Given this list of marker genes Smarca5, Setd5, Slc38a2, Mtmr3, AI182371, Trim42, Zfp84, Zfp874b, Hecw2, Ccdc171, Dlg3, Aspm, Lin28b, Six6, Prkcd, Rassf1, Nup35, Cdh7, Rbm41, Smco1, Tmem65, Crem, Carnmt1, Pou4f1, Ranbp6, Strbp, Hs3st3b1, Cpsf6, Zfp715, Pes1, Rnaseh2a, Eea1, Pgap6, Dnajc13, Ifna13, Srpk2, Nup58, Clasp2, Zbtb10, AI597479, Usp45, Fam91a1, Tead1, Gvin3, Crybg3, Zeb1, Atxn1l, Apool, Hipk1, Homer1, Nlk, Akap7, Aicda, Col17a1, Ifi44, Cdc14a, Pcgf5, Kif1b, Kcnj13, Irs1, Carf, Ccnt2, Gria2, Uty, Slc16a10, Riok3, Zfand5, Tube1, Get1, Zfp811, Vstm2a, Aass (NCBI Gene Id 30956), Unk, Jun, Oas3, Lrrc2, Mis18a, Ube2o, Tbpl2, Cnr1, Mrtfa, Irgm2, Phf20, Ccpg1, Rhoq, Psmc6, Peak1, Chd2, Mospd2, Gtse1, Itpr1, Rb1cc1, Sepsecs, Cysltr1, Cask, Nr3c2, Arid2, Txndc16, Fndc3b, Shld2, Rora, Cltc, Scn2a, Igf1, Cpeb2, Cdh11, Csnk1g3, Tma16, Ccdc169, Lmo3, Rab11a (NCBI Gene Id 53869), Zbtb44, Sgms1, Stag2, Cstf3, Smco3, Lemd3 (LEM domain containing 3), Npat, Rorb, Acap2, Lypd1, Bpnt2, Tent4a, Lman1, Wdr43, Phf8, Cdk7, Paxbp1, Kat6a, Secisbp2l, Aldh1l2, Pfkfb2, Rasa2, Or52n4, Psmb1, Sh2d3c, Lrrtm2, Epb41l5, Ppp1r21, 1810037I17Rik, Klf15, Zfp148, Ptpn2, Ubr3, Exph5, Gucy1b1, Drd1, Csnk1g1, Mcur1, Iws1, Dusp16, Ccdc103, Itga2, Slc22a23, Srp14, Bcl6, Zfr, Trhde, Tmem132b, Rftn2, Grm1, B3galt2, Ppfia1, Nxt2, Slc4a1ap, Stard13, Snx27, Ino80d, Setbp1, Ahr, Nxph2, Katnbl1, Zfp446, Slc38a1, Atf1, Zswim6, Btaf1, Tfap2b, Ptprb, Zfp354a, Magi1, Lurap1l, Vwa5a, Crebrf, Lmo4, Jpt2, Rab22a, Chrng, Pdgfd, Birc6, Suco, Clic5 (chloride intracellular channel 5), Rab1a, Pou6f2, Hspa13, Prlr, Oip5, Dnph1, Adgrg2, Pdgfra, Ndnf, Slfn4, Daam1, Dennd4a, Klf11, Ppp1r9b, Pkd2, Gmfb, Tnrc6c, Arhgap19, Grem2, Cdk5r1, Ect2, Hsd17b12, Prkacb, Mospd1, Vcam1, Sostdc1, Cul3, Creb1, Sgpp2, Map3k4, Dmxl1, Abi2, Zfp53, Max, Mrpl39, Cetn3, Actg1, Lonrf1, Ugt8a, Irf2bp2, Gata3, Gabra1, Cox16, Dnajc19, Tbcel, Asph, Cemip, Mapk8ip3, Zfp951, Agps, Golim4, Chek1, Gpcpd1 (glycerophosphocholine phosphodiesterase 1), Rfx8, Chd9, Arpc5l, Nhlrc1, Avpr1b, Atoh1, Chmp1b2, Eri1, Dhrs7, Dimt1, Bnip2, Ppat, Ppp4r3b, Macir, Rnf180, Ube3a, Zfp503, Zfp462, Rimklb, Insm2, Tmem33, Slc16a9, Rsbn1l, Brms1l, Ms4a4b, Ednra, Tpgs2, Tigd5, Rnf44, Ski, Api5, Kifbp, Ylpm1, Neurog2, Abi3bp, Synj1, Apc, Glrb (NCBI Gene Id 99751), Cntn5, Cdh2, Cenpi, Snx30, Sirt1, Arl14ep, Neu4, Upp2, Pbrm1, Dclk1, Klf4, Runx1, Mei4, Col25a1, Nwd2, Cd209a, Ahcyl2, Plch1, Dsel, Syt16, Senp7, Tmem196, Dhx15, Enox1, Ndufs1, Glo1, Spink5, Kmt2c, Nxpe3, Setd1b, Rusc2, Phip, Asxl2, Cd300a, Dop1b, Psd3, Rab9, Kctd4, Phlpp2, Lrat, Tas1r3, Plaa, Qtrt2, Pnn, Etfbkmt, Kdm2b, Tmed5, Ncoa1, Mosmo, Irf2bpl, Ptgdr, Hook3, Zfp36l2, Intu, Mblac2, Sox9, Polr3d, Enpp4, Sp1, Fgfr2, Spata13, Hivep1, Klf6, here is a description of the gene set: studied in species Mus musculus Mouse Gene Set: MIR_466B_3P_MIR_466C_3P_MIR_466P_3P Genes predicted to be targets of miRBase v22 microRNA mmu_miR_466b_3p, mmu_miR_466c_3p, mmu_miR_466p_3p in miRDB v6.0 with MirTarget v4 prediction scores > 80 (high confidence targets). from publication Chen Y, Wang X (PMID 31504780)